The following is a description of a gene set: species: Mus musculus Mouse Gene Set: GOMF_UNMETHYLATED_CPG_BINDING Binding to uan nmethylated CpG motif. Unmethylated CpG dinucleotides are often associated with gene promoters., and this is the list of marker genes: Dnmt3a, Kdm2a, Fbxl19 (NCBI Gene Id 233902), Mbd1, Kmt2a, Cxxc1, Tlr9, Mecp2 (methyl CpG binding protein 2), Kdm2b, Kmt2b